Given this list of marker genes Ccng2 (cyclin G2), Elavl2, Nfib, Trp53inp2, Sspn, Rab9, Ypel3 (NCBI Gene Id 68930), Ank3, Scp2, Mien1, Maged2, Mmp14, Calml4, Washc2, Ech1, Ndufv3, Tmem45a, Myl12b, Gaa, Atraid, Ifi27, Glod4, Mcee, Psap, Fkbp9, Ghr, Zscan21, Synpo, Trio, Plcd1, Kazald1, Cacna1a, Dpp7, Ebf1, Arf5, St3gal2, Six1, Rbms2, Pik3r1, Ap3s1 (adaptor-related protein complex 3, sigma 1 subunit), Cd276, Arsa, Lox, Phyh, Trafd1, C1ra, Actb, Dap, Ptx3, Nfix, Wdr6, Itm2b, Pdcd4, Zfp637, Col1a2, Decr1, Ablim1, Lamtor2 (NCBI Gene Id 83409), Cdk14, Mrtfa, Sptan1, Grina, Kifap3, Hsd17b11, St3gal5, Mab21l2, Ndfip1, Aplp2, Hspa2 (NCBI Gene Id 15512), Timp3, Matn2, Lamb2, Fn1, Oga, Mgst3, Kmt2e, Fkbp10 (NCBI Gene Id 14230), Tapbp, Pten, H3f3a, Six4, Dnm1, Gsta4, Cnpy2, Hcfc1r1, Gnpda1, Glmp, Atf5, Id2, Aebp1, Npc2 (NCBI Gene Id 67963), Eid1 (NCBI Gene Id 66519), Rsrp1, Naxe, Nacc2, Pkd2, Nab2, Serpine2, Lpar1, Snapin (NCBI Gene Id 99847), Gga2, Casp9, Rab11a, Csrp2, Ift25, Stx4a, Pld3, Meg3, Vegfd, Wls, Rcn1, Fibp, Ppp3ca, Ssbp2, Ndufa6, Slc12a2, Gstm2 (glutathione S-transferase, mu 2), Chmp2a, Gamt, Sdhc, Dnajb2, Copz2, Mtss2, Smad6, Vdr, Csrp1, Aldh1a1, Vps41, Nynrin, Col1a1 (NCBI Gene Id 217123), Sfrp2, Dctn2, Myo10, Tcf7l1, Ptprcap, Lrp6, Nrbp2, Ptpn13, Coq9 (coenzyme Q9), Pck2, Shc1, Cav1, Ifitm3, Dlk1, Tmem150a, Ebf3, Klf9, Pou6f1, Ogn, Snai2, Lrba (NCBI Gene Id 97082), Pdgfrb, Fscn1, Pdgfra (NCBI Gene Id 231312), Laptm4a, Cxcl12, Fkbp7, Ddit3 (NCBI Gene Id 13198), Atp6v0a1, Gstm5 (NCBI Gene Id 14866), Aldh1a7, Plat, Col6a3, Washc3, Pygb, Maged1, Eprs1, Per1, Acadm, Col5a1 (NCBI Gene Id 98940), Vkorc1, Ube2h, Ctdsp2, Tle5, Pts, Sesn1, Ctla2a, Rab3d, Bri3, Mrps34, Sema3f, Maoa, Arfgap3, Mt1, Tnfrsf11b, Gas6, Twist1, Sardh, Ptov1, Dhcr7, Itm2c, Cyb5a, Mpc2, Fgfr1, Mtarc2, Smarca2, Adam23, Plpp3, Lpin1, Ift81, Fam8a1, Zhx1, Agtr2, Igsf10, Ctnnd1, Dtd1, Gns (glucosamine (N-acetyl)-6-sulfatase), Slc38a2, Sirt2, Postn, Serpinb9, Cxxc5, Cd24a, Lama4, Jund, Atp6v0d1, Dcn, Eif2ak3, Smoc2, Sec23a, Rara, Oxct1, Sptbn1, Lyrm2, Fzd1, Pmp22, Map1lc3a, Nnmt, Ascc1, H2-T23, Kdelr3 (NCBI Gene Id 105785), Naga, St13, Pltp, Ttc3, Slc44a2, Rtraf, Ndrg3, Pias3, Cyp4v3, Lamp2, Rab24, Lss, Myorg, Atn1, Ift70b, En1, Il11ra1, Foxf1, Lum, Bhlhe40, Islr, Anxa6, Atp6v1a, Mt2, Cask, Gsn, Ifi202b, Gabarap, Cyp51 (cytochrome P450, family 51), Cln6, Zfp90, Sparcl1, Il6st, Bphl, Grb10, Prnp, Grn, Gstz1, Rnase4, Sgcb, Reck, Rin2, Thbs2, Clta, Sec31a, P2rx4, S100a13, Rasa4, Scd1, Pnp, Enah, Cpt1a, Dhrs7, Ergic3, Ly6a, Slc25a17, Ralgds, Osmr, Osbpl1a, F2r, Pla2g7, Tlr6, Lipa, Map1lc3b, Tbl1xr1, Usp22, Trappc12, Hmgcs1, Cstf2t, Akap12, Fgfr2, Nagk, Galk2, Tcf4, Itpr2, Lima1, Lama2, Ntpcr, Stx5a (syntaxin 5A), Mvd, Emb, Id3, Txnip, Nucb2 (nucleobindin 2), Anxa4, Tspyl4, Ctla2b, Snd1, Amot, Cd47 (NCBI Gene Id 78539), Arhgef25 (Rho guanine nucleotide exchange factor 25), Gstm3, Clk1, Celf2, Vps28, Rpl22, Npr3, Mrc2, Pcolce, Tcea3, Gnai2, Rras, Mroh1, Lgals9, Dkk3, Col4a5, Ugt1a2, Thra, Naalad2 (NCBI Gene Id 72560), Sec22b (SEC22 homolog B, vesicle trafficking protein), Gas1, Xdh, Ptprm, Tmem205 (transmembrane protein 205), Mapre3, Mnat1, Lxn, Id4, Lmo7, Tbx15, Prxl2a, Myo1d, Mxd4, Ltbp4, Vegfb, Meis1, Col6a2, Idh1 (isocitrate dehydrogenase 1 (NADP+), soluble), Smim14, Tom1, Rab5b, Marcks, Dcaf8, Aoc3, Pdk4, Cdo1, Cacna1g, Il17ra, Stmp1, Meis3, Txndc16, Slc1a5, Tmem59, Crybg1, Xpa, Capn6, Sel1l, Atg12, Mgp, Cyp1b1, Ccdc90b, Prrx2, Cpq, Cnn3, Ccdc80 (coiled-coil domain containing 80), Use1, Gpc4, Mnt, Ctsa, Hebp1, Gba1, Sqstm1, Ssbp4, Tm7sf3, Mkrn1, Stat3 (NCBI Gene Id 68733), Rragc, Rabac1, Hes6, Tmed3 (NCBI Gene Id 66111), Gas2, Man2a1, Cx3cl1, Tpp1, here is a description of the gene set: We have used microarray technology to identify the transcriptional targets of Rho subfamily guanosine 5'-triphosphate (GTP)ases in NIH3T3 cells. This analysis indicated that murine fibroblasts transformed by these proteins show similar transcriptomal profiles. Functional annotation of the regulated genes indicate that Rho subfamily GTPases target a wide spectrum of functions, although loci encoding proteins linked to proliferation and DNA synthesis/transcription are upregulated preferentially. Rho proteins promote four main networks of interacting proteins nucleated around E2F, c-Jun, c-Myc and p53. Of those, E2F, c-Jun and c-Myc are essential for the maintenance of cell transformation. Inhibition of Rock, one of the main Rho GTPase targets, leads to small changes in the transcriptome of Rho-transformed cells. Rock inhibition decreases c-myc gene expression without affecting the E2F and c-Jun pathways. Loss-of-function studies demonstrate that c-Myc is important for the blockage of cell-contact inhibition rather than for promoting the proliferation of Rho-transformed cells. However, c-Myc overexpression does not bypass the inhibition of cell transformation induced by Rock blockage, indicating that c-Myc is essential, but not sufficient, for Rock-dependent transformation. These results reveal the complexity of the genetic program orchestrated by the Rho subfamily and pinpoint protein networks that mediate different aspects of the malignant phenotype of Rho-transformed cells. Genes down-regulated in NIH3T3 cells (fibroblasts) transformed by expression of contitutively active (Q63L) form of RHOA off plasmid vector. from publication Berenjeno IM, Núñez F, Bustelo XR (PMID 17213802) Mouse Gene Set: BERENJENO_TRANSFORMED_BY_RHOA_DN studied in species Mus musculus